Given this list of marker genes Rps27a, Cd14, Tab2 (NCBI Gene Id 68652), Tlr4, Ubb, Tab3, Tab1, Ticam2, Ly96, here is a description of the gene set: electronically inferred by orthology from the curated human pathway Reactome Pathway: IRAK2 mediated activation of TAK1 complex upon TLR7/8 or 9 stimulation This event has been computationally inferred from an event that has been demonstrated in another species.<p>The inference is based on the homology mapping from PANTHER. Briefly, reactions for which all involved PhysicalEntities (in input, output and catalyst) have a mapped orthologue/paralogue (for complexes at least 75% of components must have a mapping) are inferred to the other species. part of: TRAF6 mediated induction of NFkB and MAP kinases upon TLR7/8 or 9 activation studied in species Mus musculus